Given this list of marker genes Aym1, Dazap1, H1f7, Spata24, Cdk7, Hmga2, Taf7, Terf2ip, Rpa1, Ctcf (NCBI Gene Id 270092), Ccnh, H2ax (H2A.X variant histone), Zmynd15, Mlh1, Taf10, Limk1, Prm2, Atr, Mael, Stpg4, Zfpm2, Terf2, Zbtb16, Pcna, Stra8, Celf1, Aire, Haspin, Ankrd17, Brca1, Rad51, Scmh1, Taf7l, Tsx (testis specific X-linked gene), Tsn, Csnk2a2ip, Smarca4, Kpna4, Tbp, Tesmin, Ran, Smad1, Prmt5, Kif6, Pou5f1, Patz1, Prm1, Topbp1, Rec8, Cdk2, Top2a, Blm, Taf3, Mlh3, Kdm3a, Hspa2, Sycp1, Sycp3, Spag8, Ankrd37, Adad1, Trip13, Zfp59, Gtf2a1l, Hmga1, Trim24, Rbmy, Smarcc1, Tsga8, Actl7a, Actrt3, Scml1, Chtf18, Taf4 (NCBI Gene Id 98977), Rad18, Spata33, Rgs22, Sohlh1 (NCBI Gene Id 277551), Top1, H1f9, Tcfl5, Stag3 (NCBI Gene Id 50878), Morc1, Tnp2, Tbpl1, Tnp1 (NCBI Gene Id 21958), here is a description of the gene set: Mouse Gene Set: GOCC_MALE_GERM_CELL_NUCLEUS The nucleus of a male germ cell, a reproductive cell in males. studied in species Mus musculus